Given this list of marker genes Igfbpl1, Itgb3, Igfbp1, Igfbp3, Igfbp2, Itga6, Igf1r (insulin-like growth factor I receptor), Igfbp4, Igf2r, Igfbp5, Igfbp6, Igfbp7, Itgb4, Igfals, Itgav, Insr, Kazald1, Lrp2, here is a description of the gene set: Mouse Gene Set: GOMF_INSULIN_LIKE_GROWTH_FACTOR_BINDING Binding to an insulin-like growth factor, any member of a group of polypeptides that are structurally homologous to insulin and share many of its biological activities, but are immunologically distinct from it. species: Mus musculus